The following is a description of a gene set: species: Homo sapiens part of: SLC transporter disorders Reactome Pathway: Defective transport of neurotransmitters by SLC6A3 causes Parkinsonism-dystonia infantile (PKDYS) The human gene SLC6A3 encodes the sodium-dependent dopamine transporter DAT which mediates the Na-dependent re-uptake of dopamine (DA) from the synaptic cleft back into cells, thereby terminating the action of DA (Broer & Gether 2012, Schweikhard & Ziegler 2012). Defects in SLC6A3 can cause Parkinsonism-dystonia infantile (PKDYS; MIM:613135), a neurodegenerative disorder characterised by infantile onset of parkinsonism and dystonia., and this is the list of marker genes: SLC6A3 (NCBI Gene Id 6531)